The following is a description of a gene set: Human Gene Set: chr13q34 species: Homo sapiens, and this is the list of marker genes: LINC03082 (NCBI Gene Id 101927646), MIR4502, TUBGCP3, GRTP1, PARP1P1, ATP4B, LAMP1 (lysosomal associated membrane protein 1), RPL21P107, ENSG00000200072, GRK1, LINC00431, TMEM255B, LINC01054, CLCP2, LINC01044, SPACA7, LINC01043, LINC00454, LINC00567, DCUN1D2, MCF2L-AS1, DCUN1D2-AS (DCUN1D2 antisense RNA), SOX1, CUL4A, COL4A2, UPF3A, LINC03032, F10, LINC01070, ADPRHL1, CFAP97D2, COL4A2-AS2, RAB20, NAXD, PRECSIT, LINC00552, PROZ, GAS6-AS1, GAS6, ARHGEF7-AS2, SWINGN, MIR8075, F7, NAXD-AS1, RPL23AP97, RASA3-IT1, LINC02337, ARHGEF7, ENSG00000287575, LINC00404, ATP11AUN, TFDP1, LINC00452 (long intergenic non-protein coding RNA 452), RN7SKP10, LINC00396, CDC16, SPACA7BP, COL4A2-AS1, ANKRD10-IT1 (ANKRD10 intronic transcript 1), RN7SL783P, TMCO3, C13orf46, ING1, CHAMP1, LINC00354, F10-AS1, MCF2L, KARS1P2, RNU1-16P, PCID2, GRTP1-AS1, SOX1-OT, ANKRD10, MIR548AR, ENSG00000283828, ATP11A-AS1, ENSG00000307285 (NCBI Gene Id 124903249), RASA3, CARS2, LDHBP1, ARHGEF7-AS1, LINC00368, LINC00676, ATP11A, MIR8073, COL4A1, ARHGEF7-IT1, TEX29, IRS2 (insulin receptor substrate 2), GAS6-DT, ENSG00000304746